The following is a description of a gene set: Mouse Gene Set: CUI_MACROPHAGE_IL3_RESPONSE_UP from publication Cui A, Huang T, Li S, Ma A, Pérez JL, Sander C, Keskin DB, Wu CJ, Fraenkel E, Hacohen N (PMID 38057668) studied in species Mus musculus Cytokines mediate cell-cell communication in the immune system and represent important therapeutic targets. A myriad of studies have highlighted their central role in immune function, yet we lack a global view of the cellular responses of each immune cell type to each cytokine. To address this gap, the authors created the Immune Dictionary, a compendium of single-cell transcriptomic profiles of more than 17 immune cell types in response to each of 86 cytokines (>1,400 cytokine-cell type combinations) in mouse lymph nodes in vivo. A cytokine-centric view of the dictionary revealed that most cytokines induce highly cell-type-specific responses. For example, the inflammatory cytokine interleukin-1β induces distinct gene programmes in almost every cell type. A cell-type-centric view of the dictionary identified more than 66 cytokine-driven cellular polarization states across immune cell types, including previously uncharacterized states such as an interleukin-18-induced polyfunctional natural killer cell state. Genes positively differentially expressed in cell type: Macrophage upon treatment with cytokine: IL-3 in mouse lymph nodes in vivo., and this is the list of marker genes: Ybx3, Ptpn1, Rab14, Plek, Odc1, Ccl9, Bcl2a1a, Cd209e, Ifi204 (NCBI Gene Id 15951), Ccl2, Pnp, Clec4n, Bcl2a1d, Dab2, Serpina3f, Srm, Serpina3g, Scimp, Cebpd, Enah, Eif4a1, Ccl7, Ccl12 (NCBI Gene Id 20293), Ccl6, Fcgr2b, Il1b, Sdc4, Ncl, Bcl2a1b, Lpl